The following is a description of a gene set: Mouse Gene Set: REACTOME_SPRY_REGULATION_OF_FGF_SIGNALING species: Mus musculus Spry regulation of FGF signaling, and this is the list of marker genes: Spry2 (NCBI Gene Id 24064), Mknk1, Uba52rt, Src (Rous sarcoma oncogene), Ppp2cb, Ubc, Uba52 (ubiquitin A-52 residue ribosomal protein fusion product 1), Rps27a, Ubb, Ppp2r1a, Ppp2ca, Grb2, Mapk1, Cbl, Braf, Ptpn11, Mapk3